Given this list of marker genes NABP1, M6PR (mannose-6-phosphate receptor, cation dependent), RNF4, RCL1, PDE3B, POLR1D, FAM107B, BTG1, CDV3, ITK, GPR171, NOLC1, MYC, EMB, RAMP3, BTLA, JAK2, NFKBID, RNF19A, MBP, RIOX1, NFKBIE, UTP25, MALT1 (MALT1 paracaspase), ENC1, ZAP70, ETF1, DDT, IL2, RGS2, CDT1, STK26, ZFP36L2, STX6, BZW1, THEMIS, DENND2D, TNFSF11, SLC29A1, ITM2A, GSTT2, PTPN22, SLFN12, GADD45B, FOXP1, TGIF1, DUSP6, ALS2, IFNG, NFATC1, GRAMD1B, POU2AF1, GCH1, UCP2, here is a description of the gene set: Genes down-regulated by FOXP3 in both ex vivo and hybridoma cells. species: Mus musculus from publication Marson A, Kretschmer K, Frampton GM, Jacobsen ES, Polansky JK, MacIsaac KD, Levine SS, Fraenkel E, von Boehmer H, Young RA (PMID 17237765) Foxp3+CD4+CD25+ regulatory T (T(reg)) cells are essential for the prevention of autoimmunity. T(reg) cells have an attenuated cytokine response to T-cell receptor stimulation, and can suppress the proliferation and effector function of neighbouring T cells. The forkhead transcription factor Foxp3 (forkhead box P3) is selectively expressed in T(reg) cells, is required for T(reg) development and function, and is sufficient to induce a T(reg) phenotype in conventional CD4+CD25- T cells. Mutations in Foxp3 cause severe, multi-organ autoimmunity in both human and mouse. FOXP3 can cooperate in a DNA-binding complex with NFAT (nuclear factor of activated T cells) to regulate the transcription of several known target genes. However, the global set of genes regulated directly by Foxp3 is not known and consequently, how this transcription factor controls the gene expression programme for T(reg) function is not understood. Here we identify Foxp3 target genes and report that many of these are key modulators of T-cell activation and function. Remarkably, the predominant, although not exclusive, effect of Foxp3 occupancy is to suppress the activation of target genes on T-cell stimulation. Foxp3 suppression of its targets appears to be crucial for the normal function of T(reg) cells, because overactive variants of some target genes are known to be associated with autoimmune disease. Human Gene Set: MARSON_FOXP3_TARGETS_DN